The following is a description of a gene set: During acute viral infections, naïve CD8+ T cells differentiate into effector CD8+ T cells and, after viral control, into memory CD8+ T cells. Memory CD8+ T cells are highly functional, proliferate rapidly upon reinfection and persist long-term without antigen. In contrast, during chronic infections, CD8+ T cells become “exhausted” and have poor effector function, express multiple inhibitory receptors, possess low proliferative capacity, and cannot persist without antigen. To compare the development of functional memory T cells with poorly functional exhausted T cells, we generated longitudinal transcriptional profiles for each. species: Homo sapiens Genes down-regulated in CD8 T cells: naïve versus effectors at day 6. Human Gene Set: GSE41867_NAIVE_VS_DAY6_LCMV_EFFECTOR_CD8_TCELL_DN from publication Doering TA, Crawford A, Angelosanto JM, Paley MA, Ziegler CG, Wherry EJ (PMID 23159438), and this is the list of marker genes: MED16, ITGAL, MACIR, MIDEAS, SESN3, CASQ1, LUC7L, SZT2, RIPOR2, ASH1L, BCL11B, FILIP1L, ATAD2B, TBC1D20, ATG101, HSD17B11, ANGPTL1, ZDHHC17, SMG6, SF1, LNPEP, INPP5F, NCOR2, NXF1, ITK, ACSL1, TGFBRAP1, FOXP1, ART3, SRF (NCBI Gene Id 6722), RELCH, RASGRP1, GRAMD2B, MYH9, SWAP70, ARHGAP25, SLC25A27, ZBTB11, CSGALNACT2 (NCBI Gene Id 55454), ARB2A, NR3C1, GNGT2, DDX54, RNF125, D2HGDH, VAT1, TPRG1L, KCTD3, IFI27, UBL3, ATP2A3, CACUL1 (CDK2 associated cullin domain 1), TFEB, ATOSB, FOXN3, INO80D, DVL1, BCL7B, MED15, PPP1R16B, TUT7, PGAP6, SRPK3, AZI2, KRTCAP3, BANK1, TUT4 (NCBI Gene Id 23318), ADCY7 (NCBI Gene Id 113), MARCHF3, SOX4, CLOCK, TMEM167B (NCBI Gene Id 56900), ATP10D, DCAF15, CYFIP1, MCOLN3, TPST2, KMT2D, PECAM1, PTAR1, KLHL24, CALCRL (NCBI Gene Id 10203), TSR2, CD300LF, CHD6, FBRS, CYRIA, CEP70, TRMT2A, CERT1, ENDOD1, CDK13, SSH2, MTSS1, SPG7, RASGRP2, F2R, NECAP1, ANGEL2, FAM120AOS, DYNC1H1, APOBEC1, TRIM44, KDM7A, KIF21B, TSC22D2, DENND1B, LDAH, TTLL3, OPALIN, ZBTB18, ELL3, CD79A, ZNF692, TESK1, VGLL4 (NCBI Gene Id 9686), SUPT20H, CEP120, UCKL1, LENG8, C1orf54, IL7R, RNF141, P2RY10, TOP3B, TAOK3, SYK, TLN1, SMG9, KIAA0930, SGPP2, MYSM1, PLEKHG2, HPS3, RAB4B, STX17, NSD1, SH3PXD2A, SKI (NCBI Gene Id 6497), RALGPS2, ARPC5, PIAS1, FBXO33, SHKBP1, ATP6V1F, SPATA13, ADGRG3, AKNA, MAP1LC3A, MTMR12, CPM, RC3H1, YPEL3, CCR7, SNX30, CNOT2, RALGDS, SIAH2, SIDT2 (NCBI Gene Id 51092), VAMP2, PHC2, CNPPD1, SCAMP3, NCSTN, CDC42EP4, SCD (NCBI Gene Id 6319), CYTH1, SMPDL3A, GLS, DYNC1LI1, PDE2A, HERC4, MAFG, RFK, ATP2B1, ZBTB2, ZNF292, SEPTIN3, ATXN7, ZMYM5, ARID5B, ASB2, SLK, MYL12B, CERK, JUNB, AKAP13, MYO18A, LRRK2, TLR6, TRIM26, PRKAG1, CDC14A, CYBB, PCMTD1, FAM13B, HPS5, SFXN5, KLF7, FKBP7